Given this list of marker genes P2RX1, DOCK5, SCNN1B, DOCK4, SLC8A1, GRIP2, MAP2K1, ADRA2B, EDN3, EDNRA, STUB1, RAP1GDS1, EDN2, MKKS, EDN1, RHOA, BBS2, MIR21, EDNRB, PIK3C2A, CD38, ZDHHC21, COMP, ARHGAP42, ACTA2, HTR2A, ATP2B1, here is a description of the gene set: A process, occurring in the vascular tissue, whereby actin/myosin complex activity generates force through ATP hydrolysis resulting in a change in smooth muscle geometry. This process is always coupled to chemo-mechanical energy conversion. Human Gene Set: GOBP_VASCULAR_ASSOCIATED_SMOOTH_MUSCLE_CONTRACTION species: Homo sapiens